The following is a description of a gene set: species: Homo sapiens Death Receptor Signaling Human Gene Set: REACTOME_DEATH_RECEPTOR_SIGNALING, and this is the list of marker genes: RELA, UBE2D3, RTN4, TAB2, OTUD1, SQSTM1, MAG, APH1B, AKAP13, USP4, OPTN, SMPD3, FGD2, HDAC2, FAS, ARHGEF17, NFKBIA, CLIP3 (NCBI Gene Id 25999), ARHGEF1, NSMAF (neutral sphingomyelinase activation associated factor), NGEF, ECT2, ARHGEF7, RPS27A, TRAF6, MAPK8, TNF, ULK1, KALRN, IKBKG, ARHGEF15, NFKB1, LINGO1, OTULIN, MAPKAPK2, UBA52, BCL2L11 (BCL2 like 11), TAB3, VAV1, SOS1, ARHGEF3, RASGRF2, TAX1BP1, ARHGEF4, NET1, PSENEN, OBSCN, TNFRSF10B, GNA13, FASLG, ARHGEF40 (Rho guanine nucleotide exchange factor 40), TNFRSF10D, IRAK1, RHOA (NCBI Gene Id 387), ARHGEF38, BIRC2, NGFR, ARHGDIA, CFLAR, RTN4R, XIAP, CASP3, PRDM4, ARHGEF26, SPPL2B, HDAC3, RNF31, HDAC1, VAV2 (vav guanine nucleotide exchange factor 2), SOS2, TRIO (trio Rho guanine nucleotide exchange factor), ARHGEF5, CASP2, PLEKHG2, USP2, MADD, RIPK2, MAP3K7 (mitogen-activated protein kinase kinase kinase 7), ARHGEF2, PRKCI, PSEN2, ARHGEF6, RAC1, CHUK, ITSN1, ARHGEF19, FGD3, FGD4, TBK1, TNFSF10, TNFRSF10A, TIAM2, UBB, AATF, ARHGEF10, APH1A, BAG4, ARHGEF18, IKBKB, RIPK1, MIB2, MCF2, PREX1, NCSTN, UBE2L3, PLEKHG5, PSEN1, TNFRSF1A, ABR, CASP8, VAV3, UBC, OMG, ARHGEF9, TRAF2, FADD, MCF2L, FGD1, ARHGEF11, SPPL2A, UBE2D2, ARHGEF33, MAGED1, USP21, TNFAIP3, BIRC3, IKBKE, CASP10, SMPD2, RACK1, ARHGEF16, BAD, SHARPIN, TRADD, BEX3, ARHGEF39, ARHGEF12, YWHAE, ADAM17, STUB1, OTUD7B, TAB1, TRAF1, CYLD, MYD88 (NCBI Gene Id 4615), ITGB3BP, SPATA2, UBE2D1, ARHGEF10L, RBCK1, ARHGEF37, TIAM1, ARHGEF35, NGF